Given this list of marker genes CHL1, TUBB, TUBA1B, SQLE, UBE2E3, CDH2, TARS1, FASN, VARS1, NCAM1, CCT8, LPL, FABP7, FDPS, ST8SIA2, CCT7, TUBA3D, L1CAM, CCT4, NRP1, TUBB2B, CCT5, USP22, TNC, MMP14, FN1, FABP5, TUBA1A, MYEF2, COL4A1, ACTG2, TBCA, ACTG1, here is a description of the gene set: species: Mus musculus from publication Mody M, Cao Y, Cui Z, Tay KY, Shyong A, Shimizu E, Pham K, Schultz P, Welsh D, Tsien JZ (PMID 11438693) We have analyzed the developmental molecular programs of the mouse hippocampus, a cortical structure critical for learning and memory, by means of large-scale DNA microarray techniques. Of genes and expressed sequence tags examined, 1,926 showed dynamic changes during hippocampal development from embryonic day 16 to postnatal day 30. Gene-cluster analysis was used to group these genes into 16 distinct clusters with striking patterns that appear to correlate with major developmental hallmarks and cellular events. These include genes involved in neuronal proliferation, differentiation, and synapse formation. A complete list of the transcriptional changes has been compiled into a comprehensive gene profile database (http://BrainGenomics.Princeton.edu), which should prove valuable in advancing our understanding of the molecular and genetic programs underlying both the development and the functions of the mammalian brain. Human Gene Set: MODY_HIPPOCAMPUS_NEONATAL Genes highly expressed in the neonatal hippocampus (clusters 4 and 8).